The following is a description of a gene set: The formation of heterochromatin into a heterochromatin domain, enriched in histone H3 methylated on lysine 9 (H3K9me), by a process mediated by a Piwi-associated RNA (piRNA). Mouse Gene Set: GOBP_PIRNA_MEDIATED_HETEROCHROMATIN_FORMATION studied in species Mus musculus, and this is the list of marker genes: Dnmt3l, Tdrd5, Ddx4, Gm38999, Mael, Piwil2, Mov10l1, Spocd1, Tdrd9, Tdrd1, Piwil4, Fkbp6 (FK506 binding protein 6), Piwil1, Dnmt3b, Tdrd12, Spin1, Tex15, Dnmt3a